Given this list of marker genes Phkg1, Ppp1r3c, Phka2, Calm3, Calm2, Ugp2, Gaa, Pygl, Pgm1, Phkb, Gys1, Akr1e1, Gbe1, Pygm, Gyg1, Agl, Phkg2, Calm1, Phka1, here is a description of the gene set: Mouse Gene Set: REACTOME_GLYCOGEN_METABOLISM species: Mus musculus Glycogen metabolism